Given this list of marker genes ABL2, GSN, ABL1, RIPOR2, DOCK8, FLOT2, here is a description of the gene set: Any process that modulates the frequency, rate or extent of establishment of T cell polarity. species: Homo sapiens Human Gene Set: GOBP_REGULATION_OF_ESTABLISHMENT_OF_T_CELL_POLARITY